Given this list of marker genes NEK6, TMEM106B, RBBP5, EFEMP1, AFF4, ABHD17C, ZNF367, FBXL3, HAT1, AP4M1, LARP4, KANSL1L, CXXC4, UCK2, NAT8L, B3GNT9, BAZ1A, MCOLN3, CCNG2, TNFSF11, CACNA1D, PAPPA, KDM2B, PPP4R1, C1QBP, PRR20A, RASGRF1, CITED2, SLC35F3, TGFBRAP1, CIBAR2, FMR1, SAT1, DAB2IP, ATP13A3, ZEB1 (zinc finger E-box binding homeobox 1), IP6K1 (NCBI Gene Id 9807), GDF6, NECTIN3, MYO1E, ARHGAP11A, SYNGAP1, IL1RAP, CNKSR2, PDE4D, NFKBIA, GNG5, NID1, LMX1A, ALX1, NET1, KAT6B, ABTB2, RNF38, HPS1, DNMT3A, JMJD1C, DCTN2, HECTD2, AP3S1, HID1, STXBP5L, PAPSS2, C1QL1, FLRT3, ZIC2, ATAD2B, REV3L, PRR20D, MAP3K20, SMG1, NCOA6, OSR2, ABCC5, KCND2, TBP, FOXJ3, CDH4, STARD4, SLAIN2, LRIG1, SGK1, ANTXR1, LRRTM3, KDM3A, C15orf40, CDH11, RAD21, TDO2, LIN28B, ARHGAP44, MBTD1, MBNL2 (NCBI Gene Id 55479), NFIA, ATXN7L3 (NCBI Gene Id 56970), COLEC12, NKX2-1, RFX3, RASL11B, SF3B1, SNRPB2, CPEB3, GABRA5, RBM27, FBXO38, HCN1, HOXA1, MAP4K3, CXCL10, RALYL, MYCBP2, RBMS1, DCUN1D1, KCNJ6 (potassium inwardly rectifying channel subfamily J member 6), CCSER1, RAI1, ATL2, ADGRG3, USP6NL, FUBP1, DYRK4, PRR20E, POLH, BAG3, MEGF11, VAV2, PGRMC2, RXRA, GRB10, ZNF341, TAB2, SLC24A2 (solute carrier family 24 member 2), FIRRM, FZD4, MEA1, GABPB1, ANP32B, PSMA5, TMTC1, AAK1, FAM43A, FAXC, PRR20C, PDGFRA, SUSD6, TOMM20, VLDLR, VAV3, VEZF1, FLT3LG, UNK, LETM2, FEZF2, PDSS2, HMGB2, CPEB2, ADGRL3, SHOC2, ARID4B, KIF13A, KRTAP4-9, FBXO34 (F-box protein 34), RTL8A, CDYL, IQCK, PRR20B, ARHGEF3, PLCB1, CD83, BCL11B, CRISPLD1, UBE2G1, TMEM130 (transmembrane protein 130), SLC35A3, ARFGEF1, DPY19L4, XPO4, TMSB4Y, CDADC1, TCF7L2, SH2B3, RAB14, CNTN1, ZFAND5, OSBPL6, GSK3B, KAT6A (NCBI Gene Id 7994), MBD5, TENM3, BCAS1, HMGN1, VANGL2, MYT1L, MXRA5, M6PR, FLRT1, RMC1, ATP5MK, CUL1, LIAS, SDC3, AKAP1, KPNA4, ATP2A2, BRD10, RAB5C (NCBI Gene Id 5878), SLC6A17, DSCAML1, PPP1CC, NECAB1 (N-terminal EF-hand calcium binding protein 1), LRP12, ZNF143, GNAL, BCL6, ZNF90, SLC20A2, RXRG, LINGO1, TMEM170B, HS6ST3, KCNK1, BCL2, ROCK1, HIVEP1, DLC1, THAP11, BBC3, ADGRL2, GGNBP2 (gametogenetin binding protein 2), ANKS1A, RBMS3, QSER1, SNAP91, EBF3, SP1, RFX4, FAT1, RORA, DACH1, SLITRK3, WTAP, PRIMA1, TSPAN3, NR2F1, SHISA6, MAGI2, KLF7, ARL8B, CADM2, CTDSPL2 (NCBI Gene Id 51496), GDNF, PCGF5, TANC2, PGAP1, USP42, C16orf54, BACH2, HS3ST1, TCAF1, TRHDE, ITGA10 (integrin subunit alpha 10), MEMO1, ITGB1, ZNF384, BAP1, BRD1, HSD11B1, FLI1, CCDC126, SP3, WIPI2, RD3L, TAOK1, TMEM165, PPARGC1A, ELAVL1, ARL8A, ZNF638, MED13L, SLITRK5, MRFAP1, NLK, SALL3, HAPLN1, EIF4ENIF1, MSH3 (NCBI Gene Id 4437), NAMPT, here is a description of the gene set: Human Gene Set: LET_7G_3P studied in species Homo sapiens from publication Chen Y, Wang X (PMID 31504780) Genes predicted to be targets of miRBase v22 microRNA hsa-let-7g-3p in miRDB v6.0 with MirTarget v4 prediction scores > 80 (high confidence targets).